Given this list of marker genes SLC6A3, here is a description of the gene set: The human gene SLC6A3 encodes the sodium-dependent dopamine transporter DAT which mediates the Na-dependent re-uptake of dopamine (DA) from the synaptic cleft back into cells, thereby terminating the action of DA (Broer & Gether 2012, Schweikhard & Ziegler 2012). Defects in SLC6A3 can cause Parkinsonism-dystonia infantile (PKDYS; MIM:613135), a neurodegenerative disorder characterised by infantile onset of parkinsonism and dystonia. studied in species Homo sapiens Reactome Pathway: Defective neurotransmitter clearance by SLC6A3 causes Parkinsonism-dystonia infantile (PKDYS) part of: SLC transporter disorders